Given this list of marker genes SSBP3, SLC38A3, CENPN, SH3GL2, DYNLT4, MRPL49, PRKAB1, ANKRD54, CDK4, FIBIN, EPCIP, RNF181, KRT82, AKR7A2, TTYH1, SEMA3C, RHOD, HASPIN, CPA1, CELA1, MRPL52, SLC8A1, LSG1, MIB1, KLK6, SLC6A14, ZP3, PRKCQ, PRMT1, CD72 (CD72 molecule), BHLHE41, CDKAL1, CDKN2D, ACOX2, SP4, MEPCE, PWP2, SPAG7, ATF5, KDELR2, C6orf132, RPL14 (NCBI Gene Id 9045), EQTN, NHERF2, HYAL3, INO80, JPH1, STARD10, TNS2, PON1, SALL2, GRAMD2B, IFIT1B, ZFPM2, SNRPD3, LY96, MRPL44, CLIC3, TWIST1, FZD3, MYT1L, SP6, GSK3B, CLCNKA, TNFRSF13B, POMC, CNOT6L, HNF1B, ZNRF1, SYNC, TMEM175, AP3B2, SPRR3, KRTAP8-1 (keratin associated protein 8-1), THOC3, PAM16 (NCBI Gene Id 51025), CABP7, BMPR2, NHERF4, SHOX2, MIA2, FLT4, ATP5IF1, ZNF354B, ZFP82, NCKAP1, TINAG, LTBP2, NDUFB11, CCND2, TSC22D1, PEX14, PLA2G12B, YEATS4, VGLL1, CHCHD6, DNASE1, PHF5A, DGCR6, PRSS37, PPP1R17, DEPDC1, B9D2, SSU72, NBN, PSMB9, NEU2, DUSP16, OLFM3, PACRG, MED28, PRPH, UXT, ZNF821, VSIG2, PTGDR (prostaglandin D2 receptor), POLR1D, ACBD6, MKKS, TNNC1, ACADS, KLK4, PITX1, TMPRSS2, AKR1C3, HOXD13, TECTB, ITGB1BP2, RPS6KL1, KRTAP15-1 (NCBI Gene Id 337962), LHPP, ZNF18, HSCB, ALOX15, FGF20, CX3CR1, SOX6, BTK, PLEKHG2, C11orf68, DOLPP1, NMBR, FAM193B, DACH1, LMBR1L, USP13, JAG2, NBEA, SMCO4, VN1R5, SARS1, MDH1, RASGRP2, RPL39, ECH1, YPEL3, MRPS15, MED22, DNER, VPREB3, TXNRD3, ACAA1, RGL2, GPR87, MRPL30, DGAT2, MYO5B, XRN1, ELAVL3, PLAC8, RBX1, EPRS1, ADIG, SORCS2, GPRC5B, LRRC41, MYBPH, CGA, GAB2, NID1, NEFH, FGF3, COL6A3, CCDC198, TK1, TNKS2 (tankyrase 2), COPS7B, MNX1, APIP (NCBI Gene Id 51074), TMEM258, LCE3B, CENPH (NCBI Gene Id 64946), EPHX2, BST2, POLD4, COCH, PIP5KL1, IBSP, PLAAT3, CUTC, here is a description of the gene set: mouse primary BMDCs were stimulated with tlr ligands and gene expression changes were profiled on Affymetrix arrays from publication Amit I, Garber M, Chevrier N, Leite AP, Donner Y, Eisenhaure T, Guttman M, Grenier JK, Li W, Zuk O, Schubert LA, Birditt B, Shay T, Goren A, Zhang X, Smith Z, Deering R, McDonald RC, Cabili M, Bernstein BE, Rinn JL, Meissner A, Root DE, Hacohen N, Regev A (PMID 19729616) Human Gene Set: GSE17721_POLYIC_VS_PAM3CSK4_0.5H_BMDC_UP Genes up-regulated in comparison of dendritic cells (DC) stimulated with poly(I:C) (TLR3 agonist) at 0.5 h versus DC cells stimulated with Pam3Csk4 (TLR1/2 agonist) at 0.5 h. species: Homo sapiens